The following is a description of a gene set: Mouse Organogenesis Cell Atlas (MOCA) DE_gene_main_cluster.csv, fold.change>=1.5, qval<0.05, pval<0.05 from publication Cao J, Spielmann M, Qiu X, Huang X, Ibrahim DM, Hill AJ, Zhang F, Mundlos S, Christiansen L, Steemers FJ, Trapnell C, Shendure J (PMID 30787437) studied in species Mus musculus Mouse Gene Set: DESCARTES_ORGANOGENESIS_MELANOCYTES, and this is the list of marker genes: Pmel, Gm15351 (NCBI Gene Id 105243124), Gpnmb, Fstl4, Rab38, Tacr3, Bhlhe41, 4930426D05Rik (NCBI Gene Id 74644), Gm15483, Chsy3, Trpm1, AW822252 (expressed sequence AW822252), Bdh2, Tyr, Clec18a, Mlana, Ephx1, 7630403G23Rik, Lsm10, Appl2, Sycp3, Gm15983, Mgll, Uap1l1 (NCBI Gene Id 277407), E130304I02Rik, Mcoln3, Col8a1, Slc38a11, Fam13a, Aph1c, Cngb3, Tyrp1, Mroh2a, Rab27a, Matn3 (NCBI Gene Id 17182), Gabra5, Wdr95, Gpr143, Mab21l2, Bace2, Mitf, Opn4, Gm20619, Kcnip2, Slc38a8, Vax2, Gm15482, Mlph, Col4a3, 1700023H06Rik, Adtrp, Pla2g5, Mtus1 (NCBI Gene Id 97469), Stra6 (NCBI Gene Id 20897), A730049H05Rik, Oca2, Or10ak14, Slc45a2, Folh1, Cntn6, Hvcn1, Syngr1, 2900064K03Rik, Cltrn, Npc1l1, Slc6a17, Aldh1a3, Gabrb3, Dtna, Cd274, Gm12153 (NCBI Gene Id 102638460), Sv2b, Ctsf, Slc24a5, Ociad2, Samd13, Dct